The following is a description of a gene set: from publication Chen Y, Wang X (PMID 31504780) Human Gene Set: MIR26B_5P studied in species Homo sapiens Genes predicted to be targets of miRBase v22 microRNA hsa-miR-26b-5p in miRDB v6.0 with MirTarget v4 prediction scores > 80 (high confidence targets)., and this is the list of marker genes: SLC35E4, UBE2G1, TENT2, PEX13, PLCB1, GPSM1, SPDYE5, PRR5L, USP53, DGKH, SCAMP1, GMDS, PALS2, TMEM265, EP400, PRKCQ, MDN1 (midasin AAA ATPase 1), RESF1, SHANK2, RGS4, NATD1, VGLL4, BID, ARL6IP6, PALM3, PIM1, ZFHX4, SLC45A4, ULK2, KLHL42, PFDN4, CDH4, USP3, PCNX1, NACC2, UBA5, PCDH9, FAM199X, ABCC4, BLOC1S2, NLK, PGM2, TTPAL, EYA3 (EYA transcriptional coactivator and phosphatase 3), CHORDC1, PECAM1, NID1 (NCBI Gene Id 4811), BFAR, UBE4B, YPEL1, PHF21A, ATP11C, ERC2, TBC1D30, SELP, GNPNAT1, RLF, CCDC28A, FBXO28, TRPC3, PHF3, RHD, PRKCD, POLR3G, ART3, ZNF516, CACNA1C, SRSF6, USP37 (NCBI Gene Id 57695), GABRA4, PLEKHG1, PAWR, EPB41L3, COL1A2, RPGR, TWF1, NT5C1B-RDH14, ACSL3 (NCBI Gene Id 55484), SAMD8, ADAM19, SH3PXD2A, HERC2, SRGAP1, SUZ12, PHF14, HOXD13, PLOD2, RDH14, ZDHHC6, USP9X, LARP1, FRAT2, PARP14, EAF1, MFSD14A, PHLDB2, CNTNAP3, TET3, SFT2D3, ARHGAP21, PCDH18, CREBZF, CRADD, PPP3CB, ABL2, CIPC, CNOT4, BEND4, ERLIN1, NUS1, CAMSAP2, ATM, MTDH, DENND1B, TRIM65, RCOR1, PMAIP1, ANKRD63, SLC1A1, SLC9A2, ACADM (NCBI Gene Id 51779), NAP1L5, PAN3, CCDC6, CREBRF, THUMPD3, POLH, FPGT, MATR3, CXADR, HGF, CDC6, NUDT11, ZNF469, RNF6, PLEKHH1, NAGPA, CHD1, MIER3, CILP, CDK8, TOB1, SOCS7, TET1, HOXA9, BOD1, NAMPT, COL19A1, MCL1 (MCL1 apoptosis regulator, BCL2 family member), HOXA5, PFKFB3, SSH2, RCN1, CTH, CARMIL1, COMMD8, PLP1, HOXC4, CEP350, LOXL2 (NCBI Gene Id 4017), SLC4A4, CNTNAP3B, ADRA1A, DOCK4, TP53INP1, HSPA8, ADAM9, FHIP1A, TAF2 (NCBI Gene Id 6873), PAK2, SERBP1 (NCBI Gene Id 51624), KLF4, CPPED1, SH3RF1, CHAC1, STRBP, CASZ1, DCDC2, UBE2J1, STK39, ZDHHC20, ELAVL2, MAT2A (methionine adenosyltransferase 2A), MRAS, SLC24A4, ZFC3H1, PIK3R3, TTPA, NCEH1, TMEM184B, BAZ2B, ACBD5, DUSP5, DMXL1, FGF18, LTBP1, NHS, MTM1 (myotubularin 1), ASPN, G2E3, TRANK1, TMEM135, MMP16, CCDC82, TOP1, PARPBP, MAP2, MICAL3, SLC5A1, ALS2, USP15, CTXN3, DAPK1, TNRC6C (NCBI Gene Id 57690), SRCAP, PSD3, ZNF598, MIER1, ARMCX2, ABHD5, RHOU, MTX2, CREBBP, SYT10, COL10A1, ADAM17, RPS6KA6, PHTF2, FLVCR1, BRWD1, APCDD1, CCND2, EIF2S1, FAM8A1, ZDHHC18, ARL5B, TBC1D15, BLTP3A, PTEN, NCOA4, DMRT3, LMLN, CEMIP2, PPP4R1, UBR3, ULK1, REST, RCN2, GMFB (NCBI Gene Id 2764), SULF1, CHSY1, ADM, GOLGA3, CTSV, CPD, ADAM23, PITPNC1, EIF5, JAG1, RSPRY1, ATP1A2, KCNQ4, MAB21L1, IL18R1, GRHL3, CPSF2, GSK3B, MLANA, DDX17, REEP3, THAP2, YTHDF3, RCC1L, SLC22A23, ICE1, TTC13, SACS, KLHL18, EPC1, ARK2N, TNNT1, GPALPP1, ANKS1A, SNX20, ZNF410, UBN2, PPP1R15B, SLC19A2 (NCBI Gene Id 7826), SLC36A4, B3GNT5, LSM11, UCK2, RAB21, TFAP2A, OSBPL11, LSM12, RNF141, MYH10, TGIF2-RAB5IF, TMEM106B, DNA2, ANKS1B, NUP50, JARID2, SLC2A14, NAB1, BAK1, PPP3R1, GMNC, BBS7, FA2H, CCNJ, TAOK1, TANC2, SKP2, MAP7, RB1, SLC38A2, CREB1, EIF4G2, CDK6, CACNB2, ETNK1, SLC25A20, PELI2, SENP5, G3BP2, ZBTB18, PDHX, SEMA6D, PAG1, IQCJ, WNK1, TMEM248, PHF6, RBM20, ZNF462, ARB2A, ZIC5, NIPA1, RAP2C, FGD1, SFXN1, ADAMTS6, RBM24, ZNF235, TMCC1, RTF1, SLC30A7, FAM98A, BBX, PHAF1, TNPO1, BHLHE40, ZNF664, CTNND2, ANKRD28, INHBB, ARPP19, MCUR1, RYK, TAF9B, STXBP5, UBE2E2, CTTNBP2NL, ITGA6, CDK2AP1, VANGL2, ATXN7 (ataxin 7), UGT8, BAG4, OSBPL2, KBTBD8 (kelch repeat and BTB domain containing 8), NAA15, BARD1, ESR1 (NCBI Gene Id 2099), B4GALT4, SLC25A16, RCBTB1, ARFGEF1, GPR52, PFKFB2, HMGA1, SLC33A1, FBXL19, ZNF608, LEF1, HAS3, SFPQ, ACVR1C, NABP1, SV2C, KCNJ2, USP25, APPL2, CELSR1, CHFR, PGRMC2, NFE2L3 (NCBI Gene Id 9603), OTUD4, CDH20, C2CD5, UBE2H (ubiquitin conjugating enzyme E2 H), MXI1, OVOL2, CAMSAP1, MAPK6, FBXO11, PHF20L1, NIPAL2, EP300, SLC16A6, MSMO1, RFK, ITGB8, KPNA2, EZH2, TRIB2, TMC7, TMEM68, PPP1R3D, ITGA5, YAF2, ZSWIM6, MAN2A1, CPED1, MAP3K7, TET2, ADAMTS19, PTPRD, PTGS2, ALDH5A1, KPNA6, TMEM260, FRMD4B, STRADB, DLG5, SSX2IP, CELF2, TMEM86A, SLC7A11, KIAA2013, SRP19, RFX3, LNX2, MARK1, LRRC2, AMOT, ZCCHC24, SLC2A13, VDAC1, CARF, FANCF, TBC1D4, NEK1, LIN28B, MKNK2, MTTP, ATPAF1, MTFMT, E2F7, AKAP7, ATAD2B, ATF2, CLASP2, HTR1B, GNA13, HEPHL1 (hephaestin like 1), ATAD1, RASSF3, HMGA2, SBNO1, EPC2, SNN, CD200, RAB5IF, TM2D3 (TM2 domain containing 3), FAM136A, TNRC6A, GABRB2, RHOQ, SMAD1, BCR, BTG1, WNK3, SEPTIN10, MAEA, RALYL, ST6GAL2, STYX, SLC25A36, TNRC6B